The following is a description of a gene set: Human Gene Set: GOMF_DNA_SECONDARY_STRUCTURE_BINDING Binding to a DNA secondary structure element such as a four-way junction, a bubble, a loop, Y-form DNA, or a double-strand/single-strand junction. studied in species Homo sapiens, and this is the list of marker genes: HMGB3, POT1, MSH2, HMGA2, HNRNPD (heterogeneous nuclear ribonucleoprotein D), MEF2C, XPC, CLSPN, ERCC5, MAPT, ABL1, XRCC2, SMC6, YY1, MEN1, LIN54, SMC5, RAD51C, H1-0, RAD18, RECQL4, RAD51B, BLM, HMGB1, GEN1, NR0B1, KMT2A, XRCC3, RAD51D, HMGA1, FANCM, WRN, HAND2, RAD51AP1, HMGB2, NEIL3, MSH6